The following is a description of a gene set: The tumor suppressor TP53 (encoded by the gene p53) is a transcription factor. Under stress conditions, it recognizes specific responsive DNA elements and thus regulates the transcription of many genes involved in a variety of cellular processes, such as cellular metabolism, survival, senescence, apoptosis and DNA damage response. Because of its critical function, p53 is frequently mutated in around 50% of all malignant tumors. For a recent review, please refer to Vousden and Prives 2009 and Kruiswijk et al. 2015. species: Homo sapiens part of: Generic Transcription Pathway Reactome Pathway: Transcriptional Regulation by TP53, and this is the list of marker genes: RRAGD, POLR2J (NCBI Gene Id 5439), BTG2, CDK9, TNFRSF10B, NOC2L, MIR26A2, RAD9B, CHD4, TAF12, BRCA1, AGO1, POLR2H, RMI2, MRE11, E2F7, STK11, AIFM2, TFDP2, PRKAB1, TP53I3, FANCC, TP53AIP1, TAF10, POLR2A, E2F8, POLR2F, TCEA1, L3MBTL1, HIGD1C, HDAC2, TAF9, AURKB, JUN, SLC38A9, RFC4, NELFB, MBD3, APAF1, GATAD2B, MAPKAP1, TAF5, COX7B, MT-CO1, MT-CO2, RRM2B, COX7A2, SUPT16H, AGO3, PRDX5, PIDD1, RBBP8, TP53BP2 (tumor protein p53 binding protein 2), GTF2H5, MT-CO3, RFFL, COX8C, COX7A2L, GTF2F1, LAMTOR4, POLR2I, NELFE, TAF1, BCL2L14, TAF13, TRIAP1, CSNK2A1, CCNT2, PRDX2, ELL, BNIP3L, TNFRSF10C, PRKAG3, TOP3A, BARD1, AKT1, CSNK2B, TXNRD1, RPA1, RHNO1, CASP1, PRR5 (NCBI Gene Id 86335), POLR2E, RHEB, RABGGTA, PRDX1, NLRC4, COX6B2, CDKN1B, PLAGL1, MAP2K6, PIP4P1, CDK2, UBA52, GTF2H2 (NCBI Gene Id 2966), EHMT1, DDB2, GSR, ATM, CNOT4, TNRC6A, TAF7L (NCBI Gene Id 79945), TAF11, CCNE2, ELOB, PCBP4, TAF7, ELOA, PTEN, TMEM219, SETD9 (NCBI Gene Id 133383), PRDM1, GPX2, RBBP4, YWHAZ, NBN, MDM4, SMYD2, POLR2G, COX4I2, PMAIP1, CCNA2, SFN, PIP4K2B, DAXX, RGCC, BID, G6PD, CNOT3, PPP1R13L, LAMTOR5, AURKA, PIN1, TNFRSF10A, POLR2K, TAF6, TAF4B, POLR2B, TAF2, KAT6A (NCBI Gene Id 7994), PRMT5, AGO4, PPP2CA, ELOA2, CNOT6, CDC25C, FOS, ERCC3, AKT3, UBC, TAF8, YWHAH, SESN2, TP53INP1 (NCBI Gene Id 94241), CDK7, CRADD, MDC1, MEAF6, YWHAB (tyrosine 3-monooxygenase/tryptophan 5-monooxygenase activation protein beta), CHEK2, TNKS1BP1, CCNH, PLK2 (NCBI Gene Id 10769), POLR2L, TXN, PIP4K2C, TP63, E2F1, GTF2H3, CNOT2, POU4F2, RFC2, ZNF385A, PPP2R5C, BCL6, NELFA, GLS2, BBC3, ING2, NPM1, POLR2C, BRPF1, AGO2, KAT5, RRAGA (NCBI Gene Id 115960), COX5A, LAMTOR3, LAMTOR1, HUS1, ELOC, PMS2, CASP10, COX6C, USP2, RRAGB, TNRC6C, RBBP7, FANCD2, CDKN2A, RMI1, JMY, MAPK11, CREBBP, CCNB1, AKT2, SSRP1, CDK13 (cyclin dependent kinase 13), YWHAE, CNOT8, E2F4, MDM2, PPP1R13B, WRN, MTOR, COX6A2, MLH1, PPP2CB, CTDP1, PIP4K2A, MTA2, CCNT1, MOV10 (NCBI Gene Id 57723), TAF9B, COX6B1, COX7A1 (NCBI Gene Id 1346), CYCS, CPAP, POU4F1, HIPK2, YWHAG, TAF4, RABGGTB, MAPK14, COXFA4, GADD45A, CDK1, EP300, PRMT1, SESN1, GTF2F2, CCNK, TNFRSF10D, MAPKAPK5, MNAT1, ATR, CSNK2A2, SUPT5H, RRAGC, USP7, ATRIP, SCO2, PLK3, CNOT6L, TP53, COX5B, RPA3, CASP6, PPP2R1B, CCNA1, MSH2, CNOT1, BLM, TP53RK (NCBI Gene Id 112858), COX4I1, PDPK1, CNOT9, EXO1, DDIT4, CCNG1, RPTOR, TFDP1, RBL2, IGFBP3, CCNE1, CNOT10, RBL1, BANP, RNF34, PML, RAD9A, SUPT4H1, ARID3A, STEAP3, RAD50, PCNA, TIGAR, NDRG1, PHF20, TP73, FAS, SESN3, CHM, GTF2H4, UBB, GATAD2A, TSC2, GPI (NCBI Gene Id 2821), NELFCD, BRD1 (bromodomain containing 1), TOPBP1, MIR26A1, BAX, COX6A1, BRPF3, TTC5, PERP, COX8A, TAF3, ING5, CNOT7, TPX2, TNRC6B, CNOT11, TSC1, ATF2, POLR2D (RNA polymerase II subunit D), GLS, RAD17, CDKN1A, BRD7, PRKAA1, PRELID3A, RPS27A (NCBI Gene Id 6233), MLST8, NUAK1, PRELID1, RAD1, EHMT2, PRKAA2, TBP (NCBI Gene Id 6908), RAD51D, CASP2, PRKAB2, RICTOR, CDK5R1, COX7C, BRIP1, DYRK2, PRKAG1, ZNF420, TAF1L, GTF2H1, CDK12, CHD3, PRKAG2, TAF15, ERCC2, FANCI (NCBI Gene Id 751608), CHEK1, CDK5, PPP2R1A, DNA2, LAMTOR2, RFC5, KMT5A, RPA2, HDAC1, CARM1, HIPK1, BIRC5, YWHAQ, RFC3, SGK1